Given this list of marker genes Zfp704, Fzd3, Mink1, Mef2d, Limk2, Cyp1b1, Krtap6-2, Dnajc1, Mecp2, Clcf1, Rbm20, Sp4, Arhgap12, Dbnl, Nefl, Pip4k2b, Rag2, Tfe3, Bmf, Qrich1, Pakap, Lhfpl3, Gins3, Thbs3, Bicd2, Erbb2, Dmrta1, Pou2f3, 2510039O18Rik, Liph, Csnk1g1, Dcx, Tfcp2l1, Brdt (NCBI Gene Id 338496), Als2 (alsin Rho guanine nucleotide exchange factor), Pip4p2, Pax9, Tmem26, Tafa1, Strip2, Cbx6, Ror1, Dlg2, Atg7, Fam53c, Sc5d, Psd3, Ndufa4, Elavl2, Vangl1, Irs1, Hoxa11, Prcp (NCBI Gene Id 72461), Phactr3, Dkk2, Smchd1, Gapvd1, H2-DMa, Amer2, Uspl1, Ebp, Paqr8, Hnrnpc, Ttll6, Tnfsf13b (NCBI Gene Id 52115), Srsf3, Eeig2, Rnf144b, Ago3, Plcg1, Sec22b, Gck, Muc15, Aldh3a2, Gria4, F13a1, Spred1, Zfp455, Ctsf, Jam2, Kcna1, Rbm14, Zfp456, Prdm15, Syne3, Nxf1, Cdh5, Smg1, Ddx19b (DEAD box helicase 19b), Rhobtb3, Cyfip2 (cytoplasmic FMR1 interacting protein 2), Frzb, Cacnb2, Ammecr1, Evx2, Cdk4 (cyclin dependent kinase 4), Txlnb, E130308A19Rik, Syndig1l, Phip, Cpeb4, Gpx1, Dennd10, Epb41l1, Eif4e, Tnrc6b, Ccdc117, Rab10, Atrn, Fgfr2, Lrrc75b, Acvrl1, Vgll3, Jph4, Spout1, Cdr2, Zfp160, Pbdc1, Nrp1, Hmgcll1, Astn1, Kdm2a, Ncam1, Katnbl1, Abraxas2, Tspan2, Wwp1, Pax7, Casp7, Ntn1, 4930562C15Rik, Mob4, Kctd6, A1cf, Plekhm3, R3hdm1, Trp53bp2, Gabpa (NCBI Gene Id 14390), Acvr2a, Epha5, Jakmip3, Arhgef33, Dip2b, Chml, Nmt1, Map3k20 (mitogen-activated protein kinase kinase kinase 20), Gbp4, Reln, Pld2, Lrp10, Cd47, Pip4k2a (NCBI Gene Id 99429), Hook3, Shisal1, here is a description of the gene set: from publication Chen Y, Wang X (PMID 31504780) Genes predicted to be targets of miRBase v22 microRNA mmu_miR_145a_3p in miRDB v6.0 with MirTarget v4 prediction scores > 80 (high confidence targets). species: Mus musculus Mouse Gene Set: MIR_145A_3P